Given this list of marker genes PNPT1, PIGA, COL6A3, SLC10A7, TELO2, ZBTB20, MYL1, BICD2, TRPV4, MYH3, ERCC8, ERGIC1, TNNT1, GNPAT, UBA1, FBN2, MUSK, RNU4ATAC, PIGY, GARS1, FKBP10 (FKBP prolyl isomerase 10), SCN4A, HS2ST1, ZC4H2, GNPTAB, BIN1, MYL11, COL25A1, SPEG, LGI4, MAP3K20, KAT6B, NFATC2, TTN, SLC6A9, P4HTM, NALCN, COL6A2, MMP2, FILIP1, TPM3, APC2, SCYL2, NSD1, LMNA, RYR1, ITGA7 (NCBI Gene Id 81988), ACTA1, RMRP, F8, MYL2, SELENON, GNB2, HSPG2, HACD1, PTH1R, PI4KA, SLC26A2, COL2A1, UNC80, TPM2, MAP3K7, ERLIN2, here is a description of the gene set: Human Gene Set: HP_HIP_CONTRACTURE Hip contracture studied in species Homo sapiens Lack of full passive range of motion (restrictions in flexion, extension, or other movements) of the hip joint resulting from structural changes of non-bony tissues, such as muscles, tendons, ligaments, joint capsules and/or skin.